Given this list of marker genes HTT, TAF4, CREB3 (NCBI Gene Id 10488), CREB3L3, PPARGC1A (NCBI Gene Id 10891), CREB3L1, CREB3L4, ATF2, ATF4, CREB1, CREB5 (NCBI Gene Id 9586), ATF6B, CREB3L2, here is a description of the gene set: Pathway Definition from KEGG: HTT* -| (CREB+TAF4) => PPARGC1A Human Gene Set: KEGG_MEDICUS_VARIANT_MUTATION_CAUSED_ABERRANT_HTT_TO_CREB_MEDIATED_TRANSCRIPTION Mutation-caused aberrant Htt to CREB-mediated transcription. Pathway ID: N00981. Pathway type: Variant. Pathway class: nt06461 Huntington disease. species: Homo sapiens